The following is a description of a gene set: studied in species Homo sapiens Human Gene Set: HP_ULNAR_BOWING Bending of the diaphysis (shaft) of the ulna. Ulnar bowing, and this is the list of marker genes: SHOX, FLNA, SCARF2 (NCBI Gene Id 91179), CHST3, IFT43, POR, FGFR3, MMP13, VPS35L, PRKG2, SLC26A2, COL11A1, RBM8A, RECQL4, RIPK4, TBX5, CCN2, HOXA11, PCNT, LAMA5, FGFR2